Given this list of marker genes Ly9, Tgfb1, Scart2, Tyk2, Tlr4, Btk, Il27ra, Ubr5, Ddit3, Il23a, Arg2, Il2, Phb1, Nr1h4, Opa1, Osm, Arid5a, Il12a, Tnfsf4, Il12b, Foxp3, Sphk1, Il15, Ccl1, Myd88, Tlr2, Il1rl2, Tusc2, Parp1, Ifng, Slc7a5, Il36rn, Slamf6, Card9, Mr1, Vsir, Il18, Otud5, Prnp, Il21, Ccn1, Jak2, Gpr141, Il6, Rftn1, Nod2, Zbtb7b, Mir301, Prkcq, Nckap1l, here is a description of the gene set: Mouse Gene Set: GOBP_INTERLEUKIN_17_PRODUCTION The appearance of any member of the interleukin-17 family of cytokines due to biosynthesis or secretion following a cellular stimulus, resulting in an increase in its intracellular or extracellular levels. species: Mus musculus